Given this list of marker genes PTGDR2, PTGER2, PTGER1, LTB4R2, CYSLTR1, GPR17, PTGER3, OXER1, TBXA2R, PTGER4, LTB4R, PTGFR, PTGIR, CYSLTR2, PTGDR, here is a description of the gene set: Eicosanoids, derived from polyunsaturated 20-carbon fatty acids, are paracrine and autocrine regulators of inflammation, smooth muscle contraction, and blood coagulation. The actions of eicosanoids are mediated by eicosanoid receptors, most of which are GPCRs. There are four types of eicosanoid GPCRs in humans; leukotriene, lipoxin (Brink C et al, 2003), prostanoid (Coleman RA et al, 1994) and oxoeicosanoid (Brink C et al, 2004) receptors. studied in species Homo sapiens Reactome Pathway: Eicosanoid ligand-binding receptors part of: Class A/1 (Rhodopsin-like receptors)